The following is a description of a gene set: Human Gene Set: WP_DISORDERS_OF_MITOCHONDRIAL_HOMEOSTATIS_DYNAMICS_PROTEIN_IMPORT_AND_QUALITY_CONTROL Disorders of mitochondrial homeostatis, dynamics, protein import, and quality control studied in species Homo sapiens, and this is the list of marker genes: MFN1, PITRM1, STAT2, MSTO1, PYCR3, LONP1, COQ5 (coenzyme Q5, methyltransferase), PRKN, UFD1, USP9X, UBXN6, GFER, OPA1, HSPD1, ADAMTSL4-AS1, DNAJC19, GDAP1L1, TXNRD2, HSPA9, MICOS13, SLC25A46, CLPB, COQ3, TIMMDC1, TIMM8A, VCP, TIMM50, CLPP, UBXN1, SACS, ATAD3A, MCL1, MARCHF5, HTRA2, OXA1L, PLEK, NPLOC4, DNM1L, MFF, PYCR1, XPNPEP3, AFG3L2, YME1L1, TXN2, PMPCA, SFXN4, SPG7, AGK, C1QBP, PYCR2, TMEM126A, PINK1, OPA3, MICU1, MIPEP, PAM16, RTN4IP1, MFN2, TRAK1, PPA2 (NCBI Gene Id 92033), AIFM1, PMPCB